Given this list of marker genes RNA4.9, SUZ12, TBL1X, ITGB1, VPS25, IRS1, UL70, UL131A, UL87, H2AC11, UL146, DYNC1I1, NUP54, UL84, H2BC17, VPS28, H2AC20, TUBB8B, UL74, UL92, US28, UL78, H2AC18, CHMP2B, UL2, TUBA3D, NUP160, UL117, TUBB2A, UL95, UL91, NUP214, TUBB1, NUP43 (NCBI Gene Id 79700), RANBP2, UL36, H2BC15, UL88, RL1, RL10, NUP85, VPS37C, UL14, DBP, TPR, UL119/UL118, UL148, H2BC5, US10, UL38, gN, CHMP1A, US13, H2BC3, UL24, UL9, TUBB8, CHMP4B, H2AC14, TUBA4B, UL147A, UL5, MCP, DYNC1LI2 (dynein cytoplasmic 1 light intermediate chain 2), US33A, UL29, H2BC9, US30, UL11, UL17, CHMP6 (NCBI Gene Id 79643), UL98, US16, RL9A, UL147, H2BC18, H2BC21, TRIM28, UL112/UL113, POM121C, VPS37B, UL80, DYNLL1, RAE1, NFKB1, NUP37, US34, H3C1 (H3 clustered histone 1), DYNLL2, UL41A, NEC2, UL47, TUBB3, UL138, TUBA1C, gL, SNF8, UL76, NUP107, CHMP3, TUBB4A, UL43, UL18, H2BC1, MVB12A, DYNC1LI1, GPS2, H2AC7, UL111A, US8, CHMP4C, US19, UL21A, H2BC12, TUBA1B, RBBP7 (NCBI Gene Id 5931), VPS37D, H4C1, TUBAL3, UL94, US23, VPS4A, UL35, SEH1L, NUP133, H2AC25, TRS1, UL132, US34A, US2, UL99, UL121, NUP93, US27, CHMP4A, UL103, UL130, NUP50, UL96, DUT, NUP153, H2AC6, CEBPD, UL122, H2BC14, EZH2, TRM2, Hh5 strain Merlin complete genome, EGFR, UL37, UL54, UL31, TUBA8, NUP155, TUBB2B (NCBI Gene Id 347733), H2AC12, TRX1, UL25, NUP205, SEC13, CHMP2A, UL34, TSG101, NCOR2, UL79, UL120, UL83, UL82, PML, NUP62, CVC1, H2BC26, TBL1XR1, UL13, CVC2, TUBA1A, TRM3, UL124, EED, UL104, H2AC1, UL97, US24, H2AC21, MVB12B, UL27, RL8A, NUP98, NUP35, NEC1, US3, TUBB4B (tubulin beta 4B class IVb), CHMP7, US22, US32, TRX2, UL16, NUP88, US11, VPS37A, H2BC4, VPS36, HNRNPK, UL23, UBAP1, TUBB6, NUP42, UL26, NDC1 (NDC1 transmembrane nucleoporin), gM, UL133, UL71, TUBA4A, US20, HELI, RBBP4, UL48, US12, DAXX, RL11, DYNC1I2, NUP210, ELK1, H2BC11, NUP188, UL4, TUBA3E, US26, UL123, UL22A, NUP58, AAAS, US9, gB, US17, UL69, UL114, US14, UL7, UL32, CREB1, H2BC13, RIR1, TUBA3C, DYNC1H1, UL102, UL52, H2AC4, NCOR1, US18, UL15A, HDAC3, CBX1, gH, TRM1, H3C15, SCP, UL144, UL44, POM121, here is a description of the gene set: Reactome Pathway: HCMV Infection part of: Viral Infection Pathways Herpesviruses have a unique four-layered structure: a core containing the large, double-stranded DNA genome is enclosed by an icosapentahedral capsid which is composed of capsomers. The capsid is surrounded by an amorphous protein coat called the tegument. It is encased in a glycoprotein-bearing lipid bilayer envelope.<br> Herpesviruses are divided into three groups: alpha-herpesviruses, beta-herpesviruses, and gamma-herpesviruses. The beta herpesviruses have a restricted host range. Their reproductive life cycle is long (days), with infection progressing slowly in cell culture systems. These viruses cause their host cells to enlarge, as exemplified by a human cytomegalovirus (HCMV) infection. These viruses can establish latent infection in secretory glands, cells of the reticuloendothelial system, and the kidneys.<br> Human Cytomegalovirus, or HCMV, is a common virus that infects people of all ages. In the United States, nearly one in three children are already infected with HCMV by age 5 years. Over half of adults by age 40 have been infected with HCMV. Once HCMV is in a person’s body, it stays there for life and can reactivate.<br> Cytomegalovirus causes three clinical syndromes:<br> (1) Congenital cytomegalovirus infection (when symptomatic) causes hepatosplenomegaly, retinitis, rash, and central nervous system involvement.<br> (2) In about 10 per cent of older children and adults, primary cytomegalovirus infection causes a mononucleosis syndrome with fever, malaise, atypical lymphocytosis, and pharyngitis.<br> (3) Immunocompromised hosts (transplant recipients and human immunodeficiency virus-infected individuals) may develop life-threatening disseminated disease involving the lungs, gastrointestinal tract, liver, retina, and central nervous system.<br> Experimentally HCMV can be propagated in multiple cell lines. When propagated in human fibroblasts, HCMV clinical isolates acquire mutations in a manner that suggests a process of adaptation. Two strains of HCMV AD169 (grown from cultures of adenoid tissue taken from a 7-year-old girl) and Towne (developed as an attenuated vaccine by passaging 125 times in vitro) were initially used as the primary clinical strains. As only 26 % of HCMV canonical genes (45/171) are essential for viral replication in vitro it became important that a model strain be developed.<br> The Merlin BAC was derived for this use. Produced using a bacterial artificial chromosome (BAC) cloning system (to avoid adaptation/degradation of the genome with each passage) the Merlin strain contains a complete HCMV genome that is thought to accurately to represent the original clinical agent from which it was derived. It is also a reproducible source of clonal virus (via transfection) and is capable of reconstituting phenotypically wild-type virus.<br><br>The lifecycle represented here uses the Merlin strain where possible.Infectious Human Cytomegalovirus (HCMV) particles enter the cell through interaction with cellular receptors. Once in the cytoplasm capsid and tegument proteins are delivered to the cytosol. The capsid travels to the nucleus, where the genome is delivered and circularized. Tegument proteins regulate host cell responses and initiate the expression of viral I immediate early genes. This is followed by delayed early genes, which initiate viral genome replication, then late genes. Late gene expression initiates capsid assembly in the nucleus, followed by nuclear egress to the cytosol. Capsids associate with tegument proteins in the cytosol and are trafficked to the viral assembly complex that contains components from the endoplasmic reticulum, Golgi apparatus, and endosomal machinery. The capsids acquire additional tegument proteins and a viral envelope by budding into intracellular vesicles. These vesicles fuse with the plasma membrane to release enveloped infectious particles along with non-infectious dense bodies. species: Homo sapiens